Given this list of marker genes Fxr1, Fto, Mettl3, Elavl1, Prr5l, Patl1, Btg2, Ybx1, Zfp64, Upf3b, Csde1, Tut4, Polr2g, Gtpbp1, Mir196a-1, Noct, Plekhn1, Cirbp, Khsrp, Rida, Cpeb3, Pde12, Samd4, Rbm24, Dcp1b, Dis3l2 (NCBI Gene Id 77551), Ttc5, Ncl, Mir451b, Eif4enif1, Mir196b, Thrap3, Dhx36, Snrnp70, Cnot6, Dazap1, Mlh1, Lsm1, Dnd1, Zfp36l2, Pan2, Pan3, Tob1, Obi1, Piwil4, Mir451a, Rbmyf3, Ago3, Lmntd2, Prdx6b (NCBI Gene Id 320769), Cnot6l, Rbmx, Cnot3, Zfp36l3, Clns1a, Cdc73, Zc3hav1, Paip1, Cnot8, Ythdf2 (NCBI Gene Id 352969), Dcp1a, Tra2b, Ythdf1, Upf3a, Tent4a, Mettl16, Ccnb1, Patl2, Zfp36l1, Dcp2, Celf1, Piwil1, Ythdf3, Adarb1, Mir196a-2, Tent4b, Celf4, Gigyf2, Tardbp, Trim71, Tnrc6c, Ncbp1, Hspa8, Pabpc1, Zfp36, Nanos1, Gm7324, Mir144, Rc3h2, Eif1, Parn, Snw1, Hnrnpu, Rc3h1, Pum1 (pumilio RNA-binding family member 1), Igf2bp1, Zc3h12a, Dhx9, Wdr77, Caprin1, Mettl14, Rbmy, Rbmxl1, Mov10, Celf3, Piwil2, Tnrc6a, Rbmyf6, Rbmyf9, Cnot1, Nanos3, Exosc10, Apobec1, Hnrnpr, Slc39a5, Fxr2, Tra2a, Pnldc1, Rbm3, Mex3d, Mir7578, Nup98, Rbmyf1, Tnrc6b, Hmx2, Eif4a3, Cnot7, Slirp, Qki, Rbmxl2, Prdx6, Rock2, Gtsf1, Dcps, Zc3h12d, Hnrnpd, Tut7, Syncrip, Prpf19, Samd4b, Prmt5, Pnpt1, Alkbh5, Cnot2, Upf1 (UPF1 RNA helicase and ATPase), Pabpn1l, Ago2, Nanos2, Rock1, here is a description of the gene set: Any process that activates or increases the frequency, rate or extent of mRNA metabolic process. Mouse Gene Set: GOBP_POSITIVE_REGULATION_OF_MRNA_METABOLIC_PROCESS species: Mus musculus